The following is a description of a gene set: Genes correlated with the late tumor onset in the Emu-myc transgenic mouse lymphoma model. Mouse Gene Set: MORI_EMU_MYC_LYMPHOMA_BY_ONSET_TIME_DN from publication Mori S, Rempel RE, Chang JT, Yao G, Lagoo AS, Potti A, Bild A, Nevins JR (PMID 18922927) studied in species Mus musculus The Emu-myc transgenic mouse has provided a valuable model for the study of B-cell lymphoma. Making use of gene expression analysis and, in particular, expression signatures of cell signaling pathway activation, we now show that several forms of B lymphoma can be identified in the Emu-myc mice associated with time of tumor onset. Furthermore, one form of Emu-myc tumor with pre-B character is shown to resemble human Burkitt lymphoma, whereas others exhibit more differentiated B-cell characteristics and show similarity with human diffuse large B-cell lymphoma in the pattern of gene expression, as well as oncogenic pathway activation. Importantly, we show that signatures of oncogenic pathway activity provide further dissection of the spectrum of diffuse large B-cell lymphoma, identifying a subset of patients who have very poor prognosis and could benefit from more aggressive or novel therapeutic strategies. Taken together, these studies provide insight into the complexity of the oncogenic process and a novel strategy for dissecting the heterogeneity of B lymphoma., and this is the list of marker genes: Gaa, Nfkbiz, Vsir (V-set immunoregulatory receptor), Csprs, Il6st, Klf6, Surf4, Itgb5, Cbx7, ENSMUSG00000079808, Hspa5, Degs1, Wdr13, Creb3l2, Pvr, Ptpn22, Hip1, Sla, Hsp90b1